The following is a description of a gene set: Genes up-regulated in Vd1 gamma delta T cells: untreated versus phorbol myristate acetate and ionomycin. from publication Kress E, Hedges JF, Jutila MA (PMID 16423401) studied in species Homo sapiens Human Gene Set: GSE3720_UNSTIM_VS_PMA_STIM_VD1_GAMMADELTA_TCELL_UP The two major human gd T cell subsets, Vd1 and Vd2, display differences in tissue tropism and agonist responses, but we have little insight into global differences that may exist at the gene expression level. This is due to the small numbers of these cells that can be obtained from healthy donors, which limit comprehensive, comparative gene expression analyses. We established a culture method that expands Vd1 and Vd2 cells from the same PBL preparation to levels sufficient for sorting and microarray analysis. Although the subsets were expanded identically (anti-TCR mAb, plus IL-15), 392 and genes were identified, which were differentially expressed in the two subsets, from two donors, respectively. Approximately genes changed in both subsets following PMA/ionomycin treatment; about 50% of these genes were subset-specific. Both subsets responded to a crude LPS preparation, but only 6% of the responsive genes were the same. The differentially expressed genes were consistent with Vd2 cells being more inflammatory and Vd1 cells having more of a regulatory phenotype. Both subsets expressed transcripts encoding an array of innate and NK cell receptors, supporting the relationship of gd T cells to the innate immune system. Our results show that circulating Vd1 and Vd2 subsets in humans have considerable, inherent differences in gene expression following treatment with non-TCR agonists, supporting unique functional roles for these cells in vivo., and this is the list of marker genes: EYA2 (EYA transcriptional coactivator and phosphatase 2), KMT5A, EMC8, CAPN11, RPL32, RPL8, MYC, CHD3, POLR3H, MAD2L1BP, RBM25, CD52, RPS3, S100A11, STXBP2, PTRH2, KBTBD11, GIMAP7, CRACR2A, C4A (NCBI Gene Id 720), ODC1, KLK8, RCSD1, MRPL16, VHL, PDLIM2, KCNIP3, CCNQP1, RPS29, RFXAP, LARP7, LSM4, PSME2, RPL22 (NCBI Gene Id 65281), CD2, RPS12, MCM5, NELFCD, PPAN (peter pan homolog, NCBI Gene Id 84997), GAB3, BEX3, RPS20, ITGAX, UBQLN1, ZNF512B, ARHGAP9, EEF1B2, MRPL33, TNFSF8, RPL19, DZIP1L (NCBI Gene Id 199221), IKBKE, SIDT1, PSMB6, GDF9, RPL27, RILPL2, EXOSC8, SLAMF6, RCN3, PIP4K2A, GTF2F2, GFM2, PPP3CC, RPL12, CRIP1, PSMB8, ERH, RNASEH2C, RPL4, ERP29, GPC2, TECPR1, PSMD12, RPL9 (ribosomal protein L9), CD8B, GAS5, IFI30, MBOAT1, NACA, TAPBPL, DNAJC19, RNASEH2B, RPS27A, RINL, DLGAP4, KAT2A, LARP1, HMGB2, BOLA2, PSMA2, ZBTB8OS, UBE2Q1, EXTL2, CLPTM1L, TSSC4, CREBL2, CHMP4B, RNF138, TPM3, PYGB, GPATCH1, PKN1, NACC1, RPL3, MEF2D, F2RL1, UTP3, PSMA6, GZMM, HSPBAP1, CWC15, NDUFS7, CCT5, GSDMD, NFKBIB, COX5B, NME2, GRK2, NDUFA1, CXCR3, RPAP2, TMSB10, IL7R, GPR183 (NCBI Gene Id 1880), LEPROTL1, NDUFB9, PDE2A, BOLA1, WDR81, MGST2, C2orf49, CYB5A, MGAT2, ZBTB22, MPC2, MAD2L1, RPS19, LTB, NKIRAS1, RPL23, GRAMD2B, ACOT7, CTPS2, RAN, ERGIC3, HEXA, H2AZ2 (H2A.Z variant histone 2), CDC37, TNFAIP8L1, PROCR, RPS14, UQCRQ, NDUFB7, CXXC1 (CXXC finger protein 1), MLX, RPSA, STARD3NL, SNAPC5, DUSP10, CD72, XPO6, LY6E, RIGI, AURKAIP1, THOC5, PACS1, EIF3H, VPS29 (VPS29 retromer complex component), COX5A, DDIT4, NOP53, MED20, ADGRL1, TRAF3IP2